The following is a description of a gene set: studied in species Homo sapiens from publication Chen Y, Wang X (PMID 31504780) Human Gene Set: MIR301B_5P Genes predicted to be targets of miRBase v22 microRNA hsa-miR-301b-5p in miRDB v6.0 with MirTarget v4 prediction scores > 80 (high confidence targets)., and this is the list of marker genes: HNF1B (NCBI Gene Id 6928), ENSG00000277067, TEX30, EEIG2, CDH17, TCF3, PKIA, LINC03105, DHX9, NR2C2, ZEB1, EIF2S2, WDR33 (NCBI Gene Id 55339), SGMS1 (NCBI Gene Id 93538), UBTD1, CIAO2A, RNF222, CCNT2, NSL1, CCM2, OSBPL3, MEA1, OTUD6B, XPO6, SNRNP27, PAPPA, NFYB, TENT5A, EFCAB11, RUFY3, MTX3, RRAS2, HK2, MASP1, PTGFR, ING2, ZNF322, ZNF12, POU2AF2, SEC24B, RAB5A, BNC2, GTF3C2, ERLIN1, FFAR2, ANKS1B, MBLAC2, PPIL3, TNPO1, HIC2, BDP1, PITPNB, PALD1, ASXL3, CALB1, TXNIP (thioredoxin interacting protein), TBC1D5, HHEX, EMC3, GPR35, AHCYL1, LINC03104, BMP2, PNMA1, RECK, CEMIP, SPIN1, PRX, ATP8A2, ZFX, COMMD8, RSPRY1, NPAS3, TM4SF20, TRAF3, PTPN12, FOXJ2, GABPA, RAB1A, CIPC, ZMYND8, HS3ST4, PDS5A, NAMPT, SEMA4B